The following is a description of a gene set: studied in species Homo sapiens The 8p11-12 chromosome region is one of the regions most frequently amplified in breast carcinoma (10-15% of cases). Several genes within this region have been identified as candidate oncogenes, as they are both amplified and overexpressed. However, very few studies have explored the role of these genes in cell transformation, with the aim of identifying valuable therapeutic targets. An analysis of comparative genomic hybridization array and expression profiling data for a series of 152 ductal breast carcinomas and 21 cell lines identified five genes (LSM1, BAG4, DDHD2, PPAPDC1B, and WHSC1L1) within the amplified region as consistently overexpressed due to an increased gene copy number. The use of small interfering RNA to knock down the expression of each of these genes showed the major role played by two genes, PPAPDC1B and WHSC1L1, in regulating the survival and transformation of two different cell lines harboring the 8p amplicon. The role of these two genes in cell survival and cell transformation was also confirmed by long-term knockdown expression studies using short hairpin RNAs. The potential of PPAPDC1B, which encodes a transmembrane phosphatase, as a therapeutic target was further shown by the strong inhibition of growth of breast tumor xenografts displaying 8p11-12 amplification induced by the silencing of PPAPDC1B. The oncogenic properties of PPAPDC1B were further shown by its ability to transform NIH-3T3 fibroblasts, inducing their anchorage-independent growth. Finally, microarray experiments on PPAPDC1B knockdown indicated that this gene interfered with multiple cell signaling pathways, including the Janus-activated kinase-signal transducer and activator of transcription, mitogen-activated protein kinase, and protein kinase C pathways. PPAPDC1B may also potentiate the estrogen receptor pathway by down-regulating DUSP22. Human Gene Set: BERNARD_PPAPDC1B_TARGETS_UP Genes up-regulated in ZR-75-1 cells (breast cancer, amplified 8p11-12 region) upon knockdown of PPAPDC1B by RNAi. from publication Bernard-Pierrot I, Gruel N, Stransky N, Vincent-Salomon A, Reyal F, Raynal V, Vallot C, Pierron G, Radvanyi F, Delattre O (PMID 18757432), and this is the list of marker genes: FRMD4A, ANP32A, TULP3, ZBTB38, GPS1, SMPD1, KLHL41, ARPC3, RSL24D1, H1-2, BLOC1S6, NPEPPS, AGPAT3, SYNJ2BP, COX7C, DENND1B, KYNU, DUSP22, CNOT2 (CCR4-NOT transcription complex subunit 2), WBP4, U2SURP, CCDC90B, MYO7A, GPATCH2, KLHL2, SNX13, TRRAP, PENK, CCSER2, ENSA, VPS53, LZIC, ZMAT3, RABL6, ANKRD44, SCFD1, COX7B